Given this list of marker genes Slc26a6, Slc15a4, Mfsd1, Slc15a3, Slc15a1, Car2, Slc15a2, Slc7a11, here is a description of the gene set: The directed movement of a dipeptide across a membrane by means of some agent such as a transporter or pore. A dipeptide is a combination of two amino acids linked together by a peptide (-CO-NH-) bond. Mouse Gene Set: GOBP_DIPEPTIDE_TRANSMEMBRANE_TRANSPORT studied in species Mus musculus